Given this list of marker genes TPO, THRB, TSHR, AIRE, PDGFRB, PMM2 (phosphomannomutase 2), TRHR (thyrotropin releasing hormone receptor), SLC16A2, SLC35A2, SMARCAL1, GLIS3, PLVAP, TG (thyroglobulin), SLC5A5, DCAF17, PAX8, PSMB8, CDH23, IYD, GNAS (GNAS complex locus), MRPS7, SMC5, SECISBP2 (NCBI Gene Id 79048), ALMS1, NKX2-5, FOXE1, SLC25A36, NKX2-1, DUOXA2, DUOX2, PRKAR1A, here is a description of the gene set: Increased concentration of thyroid-stimulating hormone (TSH) in the blood circulation. Human Gene Set: HP_ELEVATED_CIRCULATING_THYROID_STIMULATING_HORMONE_CONCENTRATION Elevated circulating thyroid-stimulating hormone concentration studied in species Homo sapiens